Given this list of marker genes H4C3, H2AJ, LIPE, H2BC14 (NCBI Gene Id 8342), H2BC9, PPARG, RXRA, CDK8, AJUBA (ajuba LIM protein), H2BC5, ACSL1, H3C8, H2BC17, RB1, SIRT1, MED10, PLIN4 (perilipin 4), CD36, MED31, EP300, MED24, PLIN2, TBL1XR1, KDM6A, MED23 (NCBI Gene Id 9439), AGPAT2, LPL, THRSP, H3C3, H2BC12L, H2BC8, H2BC10, MED6, H3C14, H4C12, MED4, H3-3B, TBL1X, H2AC6 (H2A clustered histone 6), H3C4, HDAC3, ASH2L, RBBP5, H2BC11, CREBBP, H2AZ2, NCOA3, ELOVL5, H3C1, MED12, H2BC1, H2AC18, PAXIP1, PNPLA2, H2AC20, H4C1, H2AC14, DPY30, KMT2D, MED16, H3C11, H2BC26, H2AC7 (NCBI Gene Id 3013), MED20, ADIPOQ, H2BC3, MED14, MED30, H3C13, H3C7, PPARGC1B, ACSS3 (NCBI Gene Id 79611), H4C2, MED17, SCD, H4C6, MED13, PHLDA1, H4C5, CEBPA, H2AC8, ABL1, H2BC4, H2BC21, H4C9, PAGR1, H3C15, CDK5, H2BC12, CCNC, NCOA1, NCOA6, MGLL, H2BC13, H4C14, NCOR2 (NCBI Gene Id 9612), H4C4, H2BC6, MED7, PPARGC1A, PDK4, NCOA4, MED27, H3C6, ANGPTL4, PEX11A, PLIN1, H2AB1, H2AC19, KMT2C, H4C8, MED1 (mediator complex subunit 1), H3C10, H4C13, NCOA2, WDR5, H4C11, SCD5, H4C15 (NCBI Gene Id 724021), FABP4, H3-3A, H4C16, H3C2 (NCBI Gene Id 8358), H2BC15, GPAM, DGAT2, H2BC7, CIDEC, H2AC4, NCOR1, H3C12, LPIN1, GPS2, H2AX, here is a description of the gene set: Human Gene Set: REACTOME_EPIGENETIC_REGULATION_OF_GENE_EXPRESSION_BY_MLL3_AND_MLL4_COMPLEXES Epigenetic regulation of gene expression by MLL3 and MLL4 complexes studied in species Homo sapiens